Given this list of marker genes Dcun1d4, Zfp780b, Spic, Mtor, Camk2n1, Gm15127, Specc1, Erbb4, Tmem132b, Bdnf, Kif21b, Syndig1, Zbtb2, Scfd1, Phf20l1, Gpc5, Fam120c, Ptpdc1, Fnip1 (folliculin interacting protein 1), Agl, Gm15093, Klhl38, Txlng, Odf2l, Sri, Ppargc1a, Dock4, Ccn4, B230219D22Rik, Klhl24, Rnf38 (NCBI Gene Id 73469), Tmtc1, Xrn1, Nqo2, Tnfrsf11b, Serinc1, Dnal1, Spata31d1c, Mtfr1, Arhgap42, Parg, Fbxo30, Gm15091, Bcl2l11, Kpna4, Tsc22d2, Crebrf, Trim59, Scai, Klhdc8a (kelch domain containing 8A), Capza2, Pank3, Akain1, Neurod1, Adipor1 (adiponectin receptor 1), Vps35, Id2, Gm15085, Muc15, Tada2b, Hnrnpa3, Sntb2, Ncoa2, Tmod1, Setx, Tns4, Gm15080, Rab13, Pus10, Apol11b, Bhlhe22 (NCBI Gene Id 59058), Syap1, Ppp2ca, Gorab (NCBI Gene Id 98376), Cbfb, Marchf5, Mef2a, Itga11, Zfp820, Zfp235, Mid1, Tnfaip8, Gm15114, Zfp654, Gm15097, Stag2, Nudt4, Fam120b, Hectd2, Gucy1a2, Clock, Pgam1, Ric8a, Fut9, Zfp202, Fgf7, Atad1, Rbms3, Clxn, Gfpt1, Gria4, Pdik1l, Itch, Nlrp1a, Lpcat2, Arid4b, Cacnb4, Ott, Reg1, Arhgap32, Zfp36l1, Hyal6, Slc7a14, Smg1, Tspan12, U2surp, Gtf2a1, Srxn1, Sh3kbp1, Snx4 (sorting nexin 4), Nufip2, Cadm2, Taok1, Nos1, Prune2 (NCBI Gene Id 77754), Tk2, Cavin2, Slc22a5, Wdfy2, Il6, Nsun6, Entpd7, Cops3, Cyfip2, Apol10a, Scyl3, Olfm3, Naaladl2, Plaat1, Katnbl1, Luzp4, Nfat5, Ipo11, Brip1, Pex7, Slc30a4, Glcci1, Gmfb, Gja8, Pxk, Cpeb2, Clstn1 (NCBI Gene Id 74323), Cttnbp2nl, Plxna2, Fbxl17, Cmpk1, Oscp1, Bet1, Gm94, Mtf1, Stk38, Slitrk6, Cd2ap, Dpp4, Usp29, Tmed1, Cd47, Pdxdc1, Slc5a12, Zswim5, Zbtb6, Man2a1, Zfp24, A630073D07Rik, Mmgt1, Pde5a, Them7, Cdx4, Car12, Dennd6a, Zfp39, Pigr, Plxdc2, Slc25a51, Api5, Cyp1b1, Tubb2a, Asb7, Btaf1, Zfp616, Map3k20, Tor1aip2, Flg2, here is a description of the gene set: Genes predicted to be targets of miRBase v22 microRNA mmu_miR_1966_3p in miRDB v6.0 with MirTarget v4 prediction scores > 80 (high confidence targets). from publication Chen Y, Wang X (PMID 31504780) Mouse Gene Set: MIR_1966_3P species: Mus musculus